The following is a description of a gene set: studied in species Homo sapiens Enables the transfer of an ion from one side of a membrane to the other up the solute's concentration gradient. This is carried out by binding the solute and undergoing a series of conformational changes. Transport works equally well in either direction. Human Gene Set: GOMF_ACTIVE_MONOATOMIC_ION_TRANSMEMBRANE_TRANSPORTER_ACTIVITY, and this is the list of marker genes: ATP8A1, UQCR10, UQCRFS1, CYC1, MT-ND6, ATP13A1, ATP2C1, ATP6V0D1, NDUFB9, ATP6V0C, NDUFB4, ATP1A3, MT-CO1, ATP6V1G1, ATP6V1B2, ATP6V0B, NDUFS6, NDUFA9, ATP12A, ATP6V0D2 (ATPase H+ transporting V0 subunit d2), NDUFB2, ATP6V1E2, ATP6V1A, ATP6V1G3, ABCC9, TCIRG1 (T cell immune regulator 1, ATPase H+ transporting V0 subunit a3), ATP6V1C2, NDUFS2, COX8A, ATP6V0A2, MT-ND4, NDUFA8, NDUFB3, TMEM94, NDUFV3 (NCBI Gene Id 4731), MT-ND5, NDUFB6, COX5B, NDUFV2, MT-CO3, ATP6V0A4, ATP13A2, ATP6V1E1, ATP1A1, NDUFS8, ATP13A3, UQCRFS1P1, MT-ND4L, ATP4A, MT-CYB, NDUFB8, COX5A, ATP6V1G2, NDUFA12, NDUFA10, COX7A2L, ATP4B, NDUFB10, ATP5F1B, UQCRC1, ATP6V0E2, NDUFA5, ATP2B2, ATP2A1, ATP6V1D, NDUFA1, MT-CO2, ATP2A3, KCNJ11, NDUFC2, ATP2A2, NDUFA2, ATP7B, NDUFV1, ATP13A4, NDUFA3, NDUFS1, ATP2B3, NDUFA7, ATP6V0E1, NDUFS3, SURF1, COX7B, ATP6V1C1, ATP6V1B1, NDUFA4, MT-ND1, ABCC8, MT-ND3, ATP1B1, NNT, ATP1A4, ATP2B1, ATP6V0A1, ATP7A, ATP2C2, MTCO2P12, KCNJ8, NDUFS7, NDUFB1, UQCRH, ATP1A2, ATP6V1H, COX4I1, COX6B1, ATP6V1F, ATP2B4, ATP13A5, COX7A1, NDUFS4, NDUFB5, NDUFS5, NDUFB7, NDUFC1, MT-ND2, NDUFA6